The following is a description of a gene set: Human Gene Set: GOBP_CARBOHYDRATE_PHOSPHORYLATION studied in species Homo sapiens The process of introducing a phosphate group into a carbohydrate, any organic compound based on the general formula Cx(H2O)y., and this is the list of marker genes: KHK, HK2, PFKM, RBKS, EPM2A, FGGY, HK3, NAGK, GNPTAB, FCSK, XYLB, PFKFB1, HK1, PFKFB4, POMK, GNE, TKFC, GALK1, GCK, GALK2, HKDC1, GNPTG, PFKFB3, PFKFB2